The following is a description of a gene set: Human Gene Set: GOBP_NEGATIVE_REGULATION_OF_CHOLESTEROL_EFFLUX studied in species Homo sapiens Any process that decreases the frequency, rate or extent of cholesterol efflux. Cholesterol efflux is the directed movement of cholesterol, cholest-5-en-3-beta-ol, out of a cell or organelle., and this is the list of marker genes: MIR130B, MIR33B, MAPK3, MIR206, MIR33A, MIR144, MIR19B1, MIR758, MIR613, MIR145, ABCA2, MIR17, MIR26A1, MIR128-1, SHH, MIR301B, SREBF2, MIR9-1, MIR148A, MIR27A, MIR27B, EGF, APOE, MIR93, MIR302A, PLA2G10